The following is a description of a gene set: Human Gene Set: GSE6674_CPG_VS_PL2_3_STIM_BCELL_DN We have previously shown that rheumatoid factors (RF) produced by Fas-deficient autoimmune-prone mice typically bind autologous IgG2a with remarkably low affinity. Nevertheless, B cells representative of this RF population proliferate vigorously in response IgG2a/chromatin immune complexes through a mechanism dependent on the sequential engagement of the BCR and Toll-like receptor 9 (TLR9). To more precisely address the role of both receptors in this response, we analyzed the signaling pathways activated in AM14 B cells stimulated with these complexes. We found that the BCR not only serves to direct the chromatin complex to an internal compartment where it can engage TLR9 but also transmits a suboptimal signal that in combination with the signals emanating from TLR9 leads to NF-kappa-B activation and proliferation. Importantly, engagement of both receptors leads to the upregulation of a group of gene products, not induced by the BCR or TLR9 alone, that include IL-2. These data indicate that autoreactive B cells, stimulated by a combination of BCR and TLR9 ligands, acquire functional properties that may contribute to the activation of additional cells involved in the autoimmune disease process. Genes down-regulated in B lymphocytes: CpG oligodeoxynucleotide 1826 versus PL2-3 (Chromatin IC). studied in species Homo sapiens from publication Busconi L, Bauer JW, Tumang JR, Laws A, Perkins-Mesires K, Tabor AS, Lau C, Corley RB, Rothstein TL, Lund FE, Behrens TW, Marshak-Rothstein A (PMID 18025183), and this is the list of marker genes: UBR5, SLC16A6, NAA16, DUSP6, TMEM248, MYC, COPG1, OSBPL3, DCUN1D3, TNPO1, UNC13A, HK2, CSRNP1, MIDEAS, NFIL3, SEMA4D, HAUS6, TEX10, ST3GAL4, ASNS, UBE2J2, SF3A1, RWDD1, LRATD2, GOPC, SENP6, ARF6, PRRC1, AFG2A, IMPDH1, SLC38A2, ACBD3, CLCN3, DDX42, RAD23B, DOCK10, PCID2, MYO10, HSPA9, PIM3, HMGXB4, SPRED1, MIA2, TBL2, LARS1, TPR, SEC24C, VSIR, PARVG, EPRS1, SPRY1, CAND1, BLTP3B, MARS1, CYB5R1, CYRIB, AGPAT3, GOLGA7, LARP1, CHAC1, ZNF143, COBLL1 (cordon-bleu WH2 repeat protein like 1), NCBP3, CEP295, RNF141, ALDH18A1, GABPB1, GADD45G, WRNIP1, WNK1, XPO1, NFYB, CLNK, MAF, IL24, GEM, ERRFI1, MRI1, IER3, NOL10, KCNK5, RASGRP1, USPL1, PALS2, CNNM4, ENTPD4, AQP9, SDAD1, UFL1, SAR1A, PICALM, DNAJA3 (NCBI Gene Id 94389), ARPC2, XBP1, MTHFD2, XPO4, F2R, BMP2K, VASP, CIPC, EIF2S2, TMEM186, FHL2, FNDC3A, P2RY14, HECTD1, IFRD1, TMEM163, ORC4, ROCK1, ETV3, NRDC, SHMT2, RNF126, SLC7A5, EXOC5, SYPL1 (synaptophysin like 1), U2SURP, DIP2C, ATG2B, TINF2, TEX2, ARMCX4, LRRC41, TMEM209, CSDE1, ZNF131, DNAJC21, RAB5A, SLC39A6, TRMT10C, GID4, BRD4, NUCB1 (nucleobindin 1), DAZAP1, NUP153, C15orf48, METRNL, NARS1, TAB2, HAX1, TRAF4, SLC3A2, PEX1, PKN2, GAA, PEDS1, SUZ12, EIF5, TNFRSF9, GRAMD1B, DMTF1, GARS1, GCNT1, SMC5, LIN7C, NCOA6, IARS1, EIF3A, XPOT, TNPO2, ZBED6, MRPL52, KDM6A, TMEM170B, RAP1GDS1, YARS1, PTPRE, ERN1, KCNQ5, BRAF, LATS1, IL2RB, GCH1, UBA5, NHLRC2, AARS1, NET1, BLTP3A, CHSY1, LRP12, NRF1, HDLBP, DCAF1, DENND11, AP4E1, PIK3CD, SLC25A30, SIAH2, TAMALIN, ABCC1, AHR, TPP2, MCTP2, RNF11, TRAPPC8, PRPF8, UBE2I, KCNK6, TAFA3